Given this list of marker genes NPC1, GLB1, APOE (apolipoprotein E), NPC2, SMPD1, here is a description of the gene set: Human Gene Set: HP_SEA_BLUE_HISTIOCYTOSIS Sea-blue histiocytosis studied in species Homo sapiens An abnormality of histiocytes, in which the cells take on a sea blue appearance due to abnormally increased lipid content. Histiocytes are a type of macrophage. Sea-blue histiocytes are typically large macrophages from 20 to 60 micrometers in diameter with a single eccentric nucleus whose cytoplasm if packed with sea-blue or blue-green granules when stained with Wright-Giemsa.